Given this list of marker genes Akap5, Arfgef1, Gskip, Wasf2, Acbd3, Wmp, Akap8l, 1700019D03Rik, Wasf1, Ezr, Akap11, Akap7, Arfgef2, Akap9, Kcnq1, Akap6, Akap14, Ryr2, Spatc1l, Akap1, Akap8, Prrc1, Wasf3, Prkaca, Pja2, here is a description of the gene set: Binding to one or both of the regulatory subunits of protein kinase A. Mouse Gene Set: GOMF_PROTEIN_KINASE_A_REGULATORY_SUBUNIT_BINDING studied in species Mus musculus